Given this list of marker genes Ccdc15, Cenpj, Vps4b, Plk4 (polo like kinase 4), Nup62 (NCBI Gene Id 52394), Cep120, Cep295, Sass6, Ppp1r35, Poc1b, Stil, here is a description of the gene set: studied in species Mus musculus Any process that activates or increases the frequency, rate or extent of centriole replication. Mouse Gene Set: GOBP_POSITIVE_REGULATION_OF_CENTRIOLE_REPLICATION